Given this list of marker genes SMAD7, KLF1, XRCC6, WRN, HMGA1, JUN, RELA, GATA1, HSP90AA1, NCOA3, KPNA6, MYOD1, here is a description of the gene set: The path to the discovery of suberoylanilide hydroxamic acid (SAHA, vorinostat) began over three decades ago with our studies designed to understand why dimethylsulfoxide causes terminal differentiation of the virus-transformed cells, murine erythroleukemia cells. SAHA can cause growth arrest and death of a broad variety of transformed cells both in vitro and in vivo at concentrations that have little or no toxic effects on normal cells. It was discovered that SAHA inhibits the activity of histone deacetylases (HDACs), including all 11 known human class I and class II HDACs. HDACs have many protein targets whose structure and function are altered by acetylation including histones and non-histone proteins component of transcription factors controlling gene expression and proteins that regulate cell proliferation, migration and death. SAHA is in clinical trials and has significant anticancer activity against both hematologic and solid tumors at doses well tolerated by patients. A new drug application has been approved for SAHA (vorinostat) treatment of cutaneous T-cell lymphoma. studied in species Homo sapiens from publication Marks PA (PMID 17322921) Non-histone proteins that are acetylated. Human Gene Set: MARKS_ACETYLATED_NON_HISTONE_PROTEINS